The following is a description of a gene set: The process in which the anatomical structures of the skeleton are generated and organized. Human Gene Set: GOBP_SKELETAL_SYSTEM_MORPHOGENESIS studied in species Homo sapiens, and this is the list of marker genes: DLG1, ZEB1, SIX4, SMPD3, FLVCR1, MMP16, MMP13, FOXC1, TULP3, BMP6, IFITM5, HOXB2, CSGALNACT1, HOXA5, GSC, TIFAB, ANKRD11, HOXB8, ATG9A, HYAL1, TBX15, FGF4, NEUROG1, MSX2, FGF6, SMAD2, ACP5, HOXD3, HAS2, TRIP11, TMEM107, PKD1, UNCX (UNC homeobox), RAB33B, LTBP3, BMP7, MAPK14, GLI3, SP5, TSKU, PHOSPHO1, NPR2, PCGF2, WNT9B, ALX1, SOX5, LRP5, SATB2, PDGFRA, SHOX2, TWIST1, PRKRA, INPPL1, RUNX2, SFRP4, RYK, HOXA9, SOX9, HOXC4, MGP, IHH, WNT7A, CSRNP1, COL2A1, FGFR3, FGFR2, SIX2, EXT1, PLEKHA1, SLC39A1, TBX4, HOXB3, HOXD11, IRX5, ACTN3, SCX, FGR, IFT140, HOXB6, MYF5, DLX5, HOXA4, BMP4, SGPL1, SOX11, CCN2, RIPPLY2, BMI1, LHX1, COL13A1, SMAD3, RAB23, SLC39A3, NIPBL, NOG, HOXA7 (NCBI Gene Id 3204), TCF15, CHST11, MTHFD1, ALX4, EIF4A3, NLE1, HOXC11, NAB1, TGFBR2, LAMA5, ACVR2B, NAB2, COMP, POR, HHIP, IFT80, TGFB1, VEGFA, HOXA11, HOXA3, FUZ, PRRX1, INSIG2, RARG, GLG1, HOXB4, EYA1, FBN2, GRHL2, FREM1, MYCN, OTOR, NDST1, HOXD8, MEF2C, EXT2, SIX1 (NCBI Gene Id 6495), DSCAML1, CDX1, PSEN1, THBS3, CTNNB1 (NCBI Gene Id 1499), MATN1, BARX2, PEX7, ALPL, WNT10B, MMP14, HOXB5, CITED2, RFLNA, HOXB7, PAPPA2, GALNT3, MDFI, P2RX7, MTHFD1L, AXIN2, RARB (NCBI Gene Id 5915), TMEM119, COL3A1, HOXA1, HOXD10, COL11A1, POC1A, MYC, HOXA2, MED12, TGFBR1 (transforming growth factor beta receptor 1), DHRS3, HOXD4 (NCBI Gene Id 50714), FGF18, ALX3, ATF2, FOSL2, TRPV4, SKI, CHSY1, FGF8, MMP2, HOXD9, HOXB9, MSX1, RFLNB, BPNT2, MEGF8, CHAD, DLX2, BMPR1B, TGFB2, HOXC9, WDR19, HOXB1, TFAP2A (NCBI Gene Id 95131), CYP26B1, RDH10, ZFAND5, SERPINH1, SPEF2, GREM1, COL27A1, HOXC8, OSR1, ATG9B, DCANP1, BMPR2, PAX5, TIPARP, HYAL2, WDR48, INSIG1, THRA, TBX1, LTF, BMP1, FOXN3 (NCBI Gene Id 654111), GHR, STC1, DYNC2I1, ZMPSTE24, ARID5B, SFRP1, FGFR1, NPPC, CBS, NODAL, ENSG00000274276, WWOX, SOX6, RARA, CER1, NKX3-2, OSR2, FOXC2, COL1A1